The following is a description of a gene set: Human Gene Set: PID_ERA_GENOMIC_PATHWAY from publication Schaefer CF, Anthony K, Krupa S, Buchoff J, Day M, Hannay T, Buetow KH (PMID 18832364) species: Homo sapiens Validated nuclear estrogen receptor alpha network, and this is the list of marker genes: DDX54, SMAD4, JUN, MTA1, ESR2, UBE2M, NCOA1, POU4F2, SOD1, ANP32A, TFF1, NEDD8, CHUK, MYC, MED1, LCOR, CCND1, HDAC1, MPG, NCOA2, PRL, PDIA2, ABCA3, APBB1 (NCBI Gene Id 322), NRIP1, COL18A1, EP300 (NCBI Gene Id 2033), PCNA, XBP1, KLRC3, NCOA7, CD82, SRA1, CALCOCO1, AP1B1, SAFB, HSF2, UBA3 (NCBI Gene Id 9039), TRIM59, NCOR2, SET, NCOA3, NR0B1, NR0B2, HDAC4, GREB1, DSCAM, BRCA1, EBAG9, AXIN2, PGR, DDX17, NCOR1, CEBPB (NCBI Gene Id 90277), LMO4, CTSD, NDUFV3, ATP5PF, C3, POU4F1, PRDM15, ESR1, STAT5A, PHB2